The following is a description of a gene set: Episcleritis Human Gene Set: HP_EPISCLERITIS studied in species Homo sapiens Inflammation of the episclera, a thin layer of tissue covering the white part (sclera) of the eye., and this is the list of marker genes: DNASE1L3, PSMB8, SLC29A3, MBTPS2, NLRP3